Given this list of marker genes Ccnb1ip1, Oosp1, Sf3b1, Lats1, Taf8 (NCBI Gene Id 63856), Sbds, Ndel1, Ada, Lats2, Klf4, Ttll4, 9130008F23Rik, Asf1b, Brd4, Foxd3, Rtf1, Hnf1b, Furin, Med21, Gabpa (NCBI Gene Id 14390), Psmc3, Tbl1xr1, Ndufa2, Skil, Tet1, Hs3st6, Ints1, Arhgdig, Thoc2, Ppp1cc, Thoc5, Mfn2, Elf3, Nodal, St8sia6, Eomes, Tgfbr3, Zpr1, Hand1, Cited2, Dmbt1, Stmn3, Cnot3, Zfp14, Cnot1, G2e3, Txnrd3, Cdh1, Slc25a34 (NCBI Gene Id 384071), Dicer1 (NCBI Gene Id 68462), Hopx, Pnldc1, Etv2, Slc35e2, Nlrp9b, Psmc4, Srf, Junb, Ctr9, Coprs, Pelo, Ubtfl1, Wdr74, Nle1, Ppp4r4, N4bp2l2, Acvr1c, Matr3, Tead4, Ttll1, Hcfc1, Chek1, Prdm14, Kpna7, Gins4, Zp3, Rpl7l1 (NCBI Gene Id 66229), Pramel7, Smarcb1, Hnf1a, Bysl, Nlrp9c, Pemt, Tgfbr1, Bcor, Akap3, Supt6, Crxos, Rbbp8, Tm4sf1, Sox17, Nek2, Cdx2, Nr5a2, Rad51b, Ccdc24 (NCBI Gene Id 381546), Dad1, Kdm4dl, Actl6a, Ptpn18, Esrrb, Cul3, Sall4, Capn2, Zbed6, Rbm46, Plpp4, Cmtm3, Rtn4, Sp1, Hbegf, Pbrm1, Brca2 (breast cancer 2, early onset), Ube2a, Cdk11b, Gins1, Uspl1, Nasp (NCBI Gene Id 67404), Nbn, Sf3b6, Ncapg2, Kdm4c, Npm2, Emg1, Tfap2c, Yap1, Suds3, Cnot2, Agbl4, Hormad1, Xab2, Rpl13 (ribosomal protein L13), Ankrd7, Spic, Setdb1, Igf1, Cops2, Grn (granulin), Mfng, Dcpp1, Mxi1, Rrp7a, Suv39h1, Bnip2, Phf6, Sox2, Smim14, Specc1, Nop2, Zfp420, Lpar6, Atp1b1, Zfp830, Tjp1, Prss28, Rrm2, Prss29, Sp3, Fbll1, Smarca4, Ccdc62, Palb2, Nlrp9a, Pou5f1, Necab1, here is a description of the gene set: studied in species Mus musculus Mouse Gene Set: GOBP_BLASTOCYST_DEVELOPMENT The process whose specific outcome is the progression of the blastocyst over time, from its formation to the mature structure. The mammalian blastocyst is a hollow ball of cells containing two cell types, the inner cell mass and the trophectoderm. The blastula follows the morula and precedes the gastrula in the developmental sequence.